Given this list of marker genes Adi1, Mri1, Enoph1, Apip, Mtap, here is a description of the gene set: species: Mus musculus Mouse Gene Set: GOBP_L_METHIONINE_SALVAGE_FROM_METHYLTHIOADENOSINE The generation of L-methionine (2-amino-4-(methylthio)butanoic acid) from methylthioadenosine.